The following is a description of a gene set: studied in species Homo sapiens Reactome Pathway: Defective MPDU1 causes CDG-1f part of: Diseases associated with N-glycosylation of proteins Mannose-P-dolichol utilisation defect 1 protein (MPDU1) is required for the efficient utilisation of the mannose donor dolichyl-phospho-mannose (DOLPman) in the synthesis of both lipid-linked oligosaccharides (LLOs) and glycosylphosphatidylinositols. Defects in MPDU1 can cause congenital disorder of glycosylation 1f (MPDU1-CDG, CDG-1f; MIM:609180), a multisystem disorder caused by a defect in glycoprotein biosynthesis and characterised by under-glycosylated serum glycoproteins. CDG type 1 diseases result in a wide phenotypic spectrum, such as poor neurological development, psychomotor retardation, dysmorphic features, hypotonia, coagulation abnormalities and immunodeficiency. In this condition, DOLPman is no longer utilised in transferase reactions extending LLOs, even as substrate levels and transferase enzyme activities appear normal., and this is the list of marker genes: MPDU1